Given this list of marker genes Hsd3b2, Hfe, Nos1, B2m, Heph, Iscu, Hamp, Trf, Ifng, Hamp2, Hsd3b3, Lcn2, Hsd3b6, Atp7a (NCBI Gene Id 51824), here is a description of the gene set: species: Mus musculus Mouse Gene Set: GOBP_REGULATION_OF_IRON_ION_TRANSPORT Any process that modulates the frequency, rate or extent of the directed movement of iron ions (Fe) into, out of or within a cell, or between cells, by means of some agent such as a transporter or pore.